The following is a description of a gene set: species: Homo sapiens Any process that modulates the frequency, rate or extent of lamellipodium organization. Human Gene Set: GOBP_REGULATION_OF_LAMELLIPODIUM_ORGANIZATION, and this is the list of marker genes: PLXNB3, BRK1 (NCBI Gene Id 55845), ENPP2, CORO1B, ABI2, CARMIL1, AVIL, ACTR3, ABI3, WASF2, PDPN, CFL1, PIK3R1, TWF2, CLRN1, NCKAP1, DMTN, WNT1, RAC1, MIR196A1, OCLN, FRMD7, ARPC2, MIR214, FSCN1, ACTR2, MSTN, HSP90AA1, SRC, PIK3CA, BIN3, CORO1C, VIL1, CD44, WAS (NCBI Gene Id 7454), MTOR, SLIT2, ARPIN (NCBI Gene Id 348110), CYFIP1, EPHA2, TWF1, RAC2, KANK1, AKIRIN1, RREB1, HRG, AUTS2, CDC42, FER, CARMIL2, PLCE1, ARHGEF7